The following is a description of a gene set: from publication Cui A, Huang T, Li S, Ma A, Pérez JL, Sander C, Keskin DB, Wu CJ, Fraenkel E, Hacohen N (PMID 38057668) species: Mus musculus Mouse Gene Set: CUI_CDC2_FLT3L_RESPONSE_UP Cytokines mediate cell-cell communication in the immune system and represent important therapeutic targets. A myriad of studies have highlighted their central role in immune function, yet we lack a global view of the cellular responses of each immune cell type to each cytokine. To address this gap, the authors created the Immune Dictionary, a compendium of single-cell transcriptomic profiles of more than 17 immune cell types in response to each of 86 cytokines (>1,400 cytokine-cell type combinations) in mouse lymph nodes in vivo. A cytokine-centric view of the dictionary revealed that most cytokines induce highly cell-type-specific responses. For example, the inflammatory cytokine interleukin-1β induces distinct gene programmes in almost every cell type. A cell-type-centric view of the dictionary identified more than 66 cytokine-driven cellular polarization states across immune cell types, including previously uncharacterized states such as an interleukin-18-induced polyfunctional natural killer cell state. Genes positively differentially expressed in cell type: cDC2 (conventional dendritic cell type 2) upon treatment with cytokine: FLT3L in mouse lymph nodes in vivo., and this is the list of marker genes: Myo1g, Ccnd1, Lgals3, Pfn1, Hsp90b1, Ezr, Arhgdia, Cycs, Rab3il1, Ccnd3, Lgals1, Pdia4, Ranbp1, Plec, Smdt1, Atxn2l, Rab11a, Flna, Erh, Hspa8, Cct3, Myl6, Ahnak, Ptpn7, Anxa2, Creld2, Srsf9, Cfl1, Vim